Given this list of marker genes CATSPER4, ZP1, B4GALT1, ADAM20, IZUMO3, IZUMO4, ZP2, ADAM30, CATSPER2, CATSPERG (NCBI Gene Id 57828), KCNU1, IZUMO2, CATSPER3, ZP3, ADAM21, CATSPERB, IZUMO1, ADAM2, ACR, HVCN1, CD9, ZP4, CATSPERD, CATSPER1 (cation channel sperm associated 1), OVGP1, SPAM1 (NCBI Gene Id 6677), here is a description of the gene set: species: Homo sapiens Human Gene Set: REACTOME_FERTILIZATION Fertilization